Given this list of marker genes Agpat3, Nudc, Sdad1, Mrpl12, Ddx39a, Pprc1, Erap1, Tmed2, Hspd1, Nop2, Szrd1, Trir, Fam136a, Cdv3, Ppan, Chsy1, Ssrp1, Pabpc4, Coro2a, Eif6, Srsf1, Etf1, Anp32e, Llph, Eif1, Serbp1, Shmt1, Baz1a, Pgam1, Snrpd1, Hspbp1, Btf3, Chchd4, Ndufab1, Qdpr, Canx, P4hb, Cdk4, Igfbp4, Galk1, Cnbp, Psmg4, Pim2, Cct7, Hsph1, Wdr83os, Eif3j1, Ifi47, Igtp, Thumpd1, Mrpl42, Rbmxl1, Fkbp4, Eif2s1, Nat10, Caprin1, Dlst, Hnrnpd, Cyc1, Tomm20, Prdx1, Psma5, Ruvbl2, Atf4, Irgm1, Ubtf, Mthfd1, Psma3, Lap3, Pdcd11, Rwdd1, Ybx1, Utp14a, Lars1, Fasn, Fbl, Akt1, Aatf, Ly6a, Eprs1, Eif3c, Mrpl57, Atp5f1a, Septin11, Mtdh, Kars1, Psmb3, Psme2, Rsl24d1, Hprt1, Psmb5, Rrs1, Polr2l, Ndufaf4 (NADH:ubiquinone oxidoreductase complex assembly factor 4), Ly6e, Slc35a4, Timm8a1, Idh3a, U2af2, Cyb5b, Arpc2, Phgdh, Mybbp1a, Set (NCBI Gene Id 80406), Hectd1, Psma2, Gbp7, Aprt, Rras2, Atad3a, Tbx21, Cox6a1, Ppp1r14b, Uqcr10, Irf1, Atp2a2, Pus7, Kcnq1ot1, Hsp90aa1, Psmb6, Timm17a, Eif5b, Maz, Dad1, St6galnac4, Abcf1, Trp53, Dkc1, Mrpl33, Txnl4a, Cox7b, Kpnb1 (NCBI Gene Id 16211), Utp20, Eif1a, Srsf7, Zbp1 (NCBI Gene Id 80562), Ywhaq, Ube2n, Sfpq, Nup210, Cd160, Txn1, Hnrnpa2b1, Eloc, Cops6, Srsf10 (NCBI Gene Id 14105), Actg1, Srsf3, Wdr3, Ifrd2, Casp8, Prmt1, Ruvbl1, Nudt5, Ptges3, Tspan4, Hnrnpk, Eif2s3x, Ptprcap (protein tyrosine phosphatase receptor type C polypeptide-associated protein), Ftsj3, Sec61a1, Cluh, Tapbpl, Tubb5, Shmt2, Hnrnpm, Zranb2, Stat1, Cbfb, Higd1a, Npm1, Tma16, Snrpa1, Id3, Tcerg1, Pabpc1, Psmd12, Jpt1, Tcp1, Sdhb, Hspe1, Mrps18b, Pum3 (NCBI Gene Id 68885), Gar1, Lcp1 (NCBI Gene Id 52646), Chchd2, Vdac2, Mrpl17, Ubap2l, Gnl3, Dnajc2, Ppia, Wdr43, Rrp1, Psmb2, Pebp1, Atp5f1b, Hnrnpdl, Calm3, Calm1, Sub1, Klrc1, Sars1 (NCBI Gene Id 97063), Pals2, Ran, Wdr12, Fkbp1a, Glrx3, Gtpbp4, Ung, Mrpl54, Nip7, Tomm70a, Impdh2, Srsf9, Slc25a5, Snrnp70, Nasp, Xbp1, Uqcrq, Ndufb6, Bag1, Mtap, Gnb1, Mat2a, Syncrip, Iars1, Pa2g4, Gspt1, Ddb1, Magoh, Hnrnpa3, Bst2, Rrp12, Drap1 (NCBI Gene Id 66556), Utp18, Aen, Mdh2, Ywhab, Ndufa4, Taf10, Rsl1d1, H13, Hnrnpf, Nhp2, Bysl, Mydgf, Ddx46, Eif3g, Psmd11, Cct2, Grpel1, Cyfip2, Txn2, Psmb8, Snrpd2, Acot7, Polr2h, Arcn1, Tpm4, Polr2e, Prelid3b, Ssr2, Vars1, Gpatch4, Cct4, Gnl1, Alyref, Tars1, Ctps1, Znrd2, Ltv1, Ndufb8, Pgk1, Eif3d, Eif3a, Psmb10, Tsr1, F2r, Snrpa, Psma7, Socs1, Pusl1, Mrps14 (NCBI Gene Id 98490, mitochondrial ribosomal protein S14), Pitpna, Tcof1, Rasa2, Polr1d, Fabp5, Noc2l, Stat3, Nop14, Serpina3g, Gbp4, Pbdc1, Septin9, Rars1, Naa15, Atp5pb, Snrpb, Ndufs6, Tfdp1, Prelid1, Pcbp1, Ipo4, Ptma, Emg1, Nars1, Magohb, Dnajc11, Psme1, Aldoa, Mars1, Banf1, Pak1ip1, Ccdc115, Atic, Bccip, Gpr18, Lsm4, Ranbp1, Parp9, Rad23b, Pdia6, Tomm40, Polr1b (polymerase (RNA) I polypeptide B), Psmb4 (proteasome (prosome, macropain) subunit, beta type 4), Ssb, Yrdc, Stip1, Lrpprc, Gars1, Zfp106, Exosc3, Bop1, Uqcc2, Hdgf, Gcsh, Bcap29, Trmt61a, Capg, Ddx18, Bcl3, Ppid, Lsm7, Ccdc86, Vdac1, Cct8 (NCBI Gene Id 12469), Ddx17, Gzmb, Fcer1g, Pdia3, S100a6, Rbbp7, Iigp1, Eno1, Snrpf, Rcl1, Thy1, Tmed9, Gbp2, Kmt5a, Mak16, Psme3, Ube2l3, Zfp706, Hspa8, Pomp, Ppa1 (pyrophosphatase (inorganic) 1), Pkm, Lyar, Hopx, Hnrnpr, Atp5mc1, U2af1, Nop10, Fyn, Apex1, Tomm5, Tpm3, Pno1, Cdca7, Sumo2, Nop58, Ebna1bp2, Dnajb11 (NCBI Gene Id 67838), Lgals3bp, Ndufaf8, Notch1, Timm10, Krtcap2, Nomo1, Grwd1, Mcm2, Prpf31, Polr1a, Pfdn4, Dtx1, Rexo2, Timm9, Rtp4, Hint1, Erh, Polr2f, Aldh18a1, Arhgdia (NCBI Gene Id 77176), Sf3b3 (splicing factor 3b, subunit 3), Mrpl23, Flt3l, Eif1ax, Nup62, Phf5a, Ywhag, Sar1a, Capzb, Clic4, Mrpl15, Pim1, Ewsr1, Slc29a1, Heatr1, Pop5, Bax, Vapa, Rangap1, Lsm6, Eif5a, Cct3, Gls, Tap2, Uck2, Tbca, Slc3a2, Prpf19, Mrpl52, Tmem238, Gpx1, Ywhae, Mrps28, Tuba4a, Cdk6, Npm3, Spcs3, Vim, Micos10, Tmed5, Cish, Ddx27, Uchl3, Nme1, Got2, Eif4h, Itgb2, Itgal, Tpi1, Eef1e1, Bzw1, Rrp15, Hspa9, Nifk, Znhit6, Gimap4, Slc7a1, Sf3b5, Fubp1, Utp3, Pole4, Mbd3, Rpn1, Psmd6, Efhd2, Rad23a, Nkg7, Calr, Pfdn2, Prpf40a, Atp5f1d, Nap1l1 (nucleosome assembly protein 1-like 1), Srsf6, Lsm12, Atp5mc3, Mcm6 (minichromosome maintenance complex component 6), Nop16, Ube2s (ubiquitin-conjugating enzyme E2S), Ndufb2, Ly6c2, Mcm3, Ipo5, Snu13, Smarca5, Wdr46, Smyd2, St13, Slamf7, Tardbp, Brix1, Ddx3x, Ctsz (NCBI Gene Id 99199), Ndufb4, Ipo7, Lsm2 (NCBI Gene Id 27756), Cdc34, Glrx5, Rbm3, Ostc, Ubl4a, Esf1, Selenow, Wars1, Tkt, Nolc1, Wdr77, G3bp1, Eif2b3, Zfp593, Nol11, Pdap1, Atp5mk, Sco2, Xcl1, Ccnd2, Mthfd2, Hspa4, Eif4g2, Nsun2, Lat, Gapdh, Aimp2, Cct5, Cox5a, Dph3, Dynll2, Bsg, Ubald2, Umps, Arpc1b, Psmd7, Nop56, Ldha, Manf, Xpot, Pfdn6, Phb2, Tfrc, Gmfb, Mia2, Larp4, Timm13, Rbx1, Cox5b (cytochrome c oxidase subunit 5B), Tasor2, Eif4a1, Nudcd2, Eif4g1, Aars1, Fkbp2, Irf8, Psmd3, Dctpp1, Larp1, Cycs (cytochrome c, somatic), Phb1, Metap2 (NCBI Gene Id 78359), Pdcd5, Gadd45g, Tuba1b, Vma21, Prpf8, Snrpd3, Srm, Tuba1c, Tnk2, Bcl2, Rangrf, Socs3, Slc19a1, Cyba, Ncl, Imp4, Taf5l, Mdn1, Ppat, Rcc2, Hsp90ab1, Abce1, Tubb4b, Ndufb7, Nucks1, Rac1, Hsp90b1, Rrp9, Dtx3l, Ola1 (NCBI Gene Id 78355), Eif2s2, Mrpl20, Ndufc2, Agpat5, Ppp4c (NCBI Gene Id 56420), Sema4a, Jaml (NCBI Gene Id 270152), Cacybp, Smarcc1, Psma6, Emc6, Tap1, Sdf2l1, Cndp2, Dtymk, Agfg1, Lta, Polr1g, Chchd1, Psat1, Cfl1, Mettl1, Ddx21, Denr, Dynll1, Pfkp, Psma4, Yars1, Snrpe, Actr2, Fam162a, Mrpl36, Eif3b, Acsl5 (NCBI Gene Id 71879), Ptpn7, Ak2, Ost4, Hnrnpab, Dnaja2, Slc1a5, Nefh, Srsf2, Ppif, Mphosph10, C1qbp, Eif4e, Ndufa12, Anp32b, Ssr1, Cars1, Vasp, Pfn1, Bzw2, Hnrnpu, Mrto4, Mthfd1l, Mif, Dnajc19, Odc1, Strap, Pcna, Rpf2, Il2rb, Mrpl51, Psmb7, Hspa5, Mrpl3, Rrp1b, Ybx3, Rbm8a, Gart (NCBI Gene Id 14450), Sfxn1, Nlrc5, Paics, here is a description of the gene set: Mouse Gene Set: CUI_T_CELL_CD8_IL2_RESPONSE_UP from publication Cui A, Huang T, Li S, Ma A, Pérez JL, Sander C, Keskin DB, Wu CJ, Fraenkel E, Hacohen N (PMID 38057668) Genes positively differentially expressed in cell type: CD8+ T cell upon treatment with cytokine: IL-2 in mouse lymph nodes in vivo. Cytokines mediate cell-cell communication in the immune system and represent important therapeutic targets. A myriad of studies have highlighted their central role in immune function, yet we lack a global view of the cellular responses of each immune cell type to each cytokine. To address this gap, the authors created the Immune Dictionary, a compendium of single-cell transcriptomic profiles of more than 17 immune cell types in response to each of 86 cytokines (>1,400 cytokine-cell type combinations) in mouse lymph nodes in vivo. A cytokine-centric view of the dictionary revealed that most cytokines induce highly cell-type-specific responses. For example, the inflammatory cytokine interleukin-1β induces distinct gene programmes in almost every cell type. A cell-type-centric view of the dictionary identified more than 66 cytokine-driven cellular polarization states across immune cell types, including previously uncharacterized states such as an interleukin-18-induced polyfunctional natural killer cell state. species: Mus musculus